Given this list of marker genes Pkmyt1, Ccna2, Ccnb2, Ccnb1, Ccna1, Wee1, Cdk1, here is a description of the gene set: G2/M DNA replication checkpoint Mouse Gene Set: REACTOME_G2_M_DNA_REPLICATION_CHECKPOINT studied in species Mus musculus